The following is a description of a gene set: Any process that activates or increases the frequency, rate or extent of postsynaptic membrane organization. Mouse Gene Set: GOBP_POSITIVE_REGULATION_OF_POSTSYNAPTIC_MEMBRANE_ORGANIZATION studied in species Mus musculus, and this is the list of marker genes: Zdhhc2, Ssh1, Dlg4, Grip2, Snx27